Given this list of marker genes PRKCA, PLCB2, PLCB3, CHRM3, MARCKS, GNAQ, GNA15, GNA11, PLCB1 (phospholipase C beta 1), GNA14, here is a description of the gene set: Reactome Pathway: Acetylcholine regulates insulin secretion part of: Regulation of insulin secretion Acetylcholine released by parasympathetic nerve endings in the pancreas causes a potentiation of insulin release when glucose is present at concentrations greater than about 7 mM. Acetylcholine binds the Muscarinic Acetylcholine Receptor M3 on pancreatic beta cells. The binding has two effects: an increase in permeability of the cell to Na+ ions through an unknown mechanism, and the activation of Phospholipase C beta-1 through a heterotrimeric G protein, G(q).<br>After acetylcholine binds the Muscarinic Acetycholine Receptor M3, the receptor activates the G protein Gq by causing the alpha subunit of Gq to exchange GDP for GTP. Activation of Gq in turn activates Phospholipase C beta-1. Phospholipase C beta-1 hydrolyzes the phosphodiester bond at the third position of phosphoinositol 4,5-bisphosphate, producing diacylglycerols (DAG) and inositol 1,4,5-trisphosphate.<br>DAG remains in the cell membrane and causes Protein Kinase C alpha (PKC alpha) to translocate from the cytosol to the membrane. This results in the activation of PKC alpha which then phosphorylates target proteins on serine and threonine residues. One known target of PKC alpha is Myristoylated Alanine-rich C Kinase Substrate (MARCKS), which is believed to affect vesicle transport and may be responsible for the increased traffic of insulin granules seen in response to acetylcholine.<br>Inositol trisphophate binds a receptor, the IP3 receptor, on calcium stores in the cell (probably the endoplasmic reticulum). The release of calcium into the cytosol stimulates the exocytosis of insulin granules. studied in species Homo sapiens